The following is a description of a gene set: from publication Chen Y, Wang X (PMID 31504780) species: Homo sapiens Genes predicted to be targets of miRBase v22 microRNA hsa-miR-219a-2-3p in miRDB v6.0 with MirTarget v4 prediction scores > 80 (high confidence targets). Human Gene Set: MIR219A_2_3P, and this is the list of marker genes: ZIC3, FAM227B, DSCAM, RORA, DACH1, CBR4, TENM1, TRMT10C, COL12A1, INTS2, SEPHS1, VRK1, HSP90AA1, KLHL24, COL3A1, ZNF20, KHDRBS2, SYNJ1, ATXN7L1, GABRP, SUV39H2 (NCBI Gene Id 79723), F11, RCAN1, ZNF239, CRLF3, HSPH1, ZNF99, ZNF813 (zinc finger protein 813), TBK1 (TANK binding kinase 1), STAU2, XKR3, LRIF1, ZNF184, FMN2, DHX57, CERS6, NUSAP1, PPCS, KRT8, GALC, PLSCR4, C17orf75, ENC1, RSBN1L, DIDO1, OTUD4 (NCBI Gene Id 95936), MINK1, C9orf152, C5orf24, SORD, IDO2, ANKIB1, TPK1, DLGAP1, PPFIA1, USP45, IFI44L, SLC6A15, PGM3, CHAC2, MPHOSPH9, DDC, FSD2, RBFOX1, SERAC1, APOC2, USP49